The following is a description of a gene set: HDMs demethylate histones species: Mus musculus Mouse Gene Set: REACTOME_HDMS_DEMETHYLATE_HISTONES, and this is the list of marker genes: Kdm6a, H3c14, Uty, Kdm4d, Jmjd6, H4c11, Kdm5c, H4c1, Kdm2b, Kdm5d, Kdm6b, H4c9, H3c4, Kdm4c, H3c3, Kdm2a, Kdm7a, Kdm4b, Kdm4a, H4c17, Riox2, H3c6, H3c2, H4c12, Phf8, H4c4, H4c6 (NCBI Gene Id 319157), H4c16, Kdm5a, Phf2, H4c3, Kdm1a, Arid5b, H3c1, H4c18, H4c8, H3c15, Kdm3a, H3c8, H4c14, H3c13, Kdm3b, H3c7, H3c10, H4c2, H3c11, Kdm5b, Kdm1b